Given this list of marker genes PHOSPHO1, MMP14, SCX, MMP13, BMP6, NAB2, COL13A1, MEF2C (NCBI Gene Id 4208), COL1A1, TMEM119, SMPD3, FGF18, CSGALNACT1, PEX7, MMP16, BPNT2, BMP4, INPPL1, COL2A1, ENSG00000274276, GALNT3, EXT1, IFT80, DLX5, FGFR3, FOXC1, ALPL, NAB1, CBS, NPR2, RUNX2, here is a description of the gene set: studied in species Homo sapiens Human Gene Set: GOBP_REPLACEMENT_OSSIFICATION Ossification that requires the replacement of a preexisting tissue prior to bone tissue formation.